The following is a description of a gene set: from publication Abbas AR, Wolslegel K, Seshasayee D, Modrusan Z, Clark HF (PMID 19568420) studied in species Homo sapiens Genes down-regulated in comparison of naive T cells versus effector memory T cells. Human Gene Set: GSE11057_NAIVE_VS_EFF_MEMORY_CD4_TCELL_DN Microarray deconvolution is a technique for quantifying the relative abundance of constituent cells in a mixture based on that mixture's microarray signature and the signatures of the purified constituents. It has been applied to yeast and other systems but not to blood samples. Here we test the ability of this technique to determine the fractions of subsets of memory T cells in peripheral blood mononuclear cell (PBMC) samples., and this is the list of marker genes: NPC1, CD84, SMCO4, B3GNT9, GCLM, MDFIC, LACC1, TMX4, NABP2, ZC3HAV1L, ATXN1, ANXA2, EVI2B, PREX1, MYO1F, CRELD2, RNF149, RORA, RNF126, MFHAS1 (multifunctional ROCO family signaling regulator 1), CLDND1, UST, LGALS1, CD58, ZBTB38, OSBPL3, CREB3L2, LIMS1, SEC11C, CLU, SRGN, RGS3 (regulator of G protein signaling 3), ARHGAP18, ANXA4, ANXA1, PFKL, YWHAH, MIB1, MICAL2, ATP2B4, REEP3, SSR3, TNFRSF4, NCAPH, CAPG, KLRB1, PPIF, TMEM64, GZMK, SAP30, MYBL1, CXCR3, FAS, CDC42EP3, ANTXR2, DUSP16, TBX21, SH3BP5, ADAM19, PPP1CA, RHOU, EFHD2, IFNG, S100A4, CCDC107, PHTF2, MIAT, GBP3, PRR5L, TIGIT, DUSP5, IFI27, CPPED1, GOLGA7, NOD2, NETO2, SLF1, SLC35D2, TMEM200A, CRYBG3, PDIA6, KIF1B, CLIC1, TOR3A, CD63, TTYH2, OGDH, CD28, NMU, MLF1, ACTN4, SMIM29, EIF4EBP2, CBLL1, FBXL8, CD74, EPS15, LGALS3, IL15RA, PEA15, OGFRL1 (NCBI Gene Id 79627), CNPPD1, HLA-DPA1, TLR3, CRIP1, ASB2, PAM, TTC39C, ZNF532, TMEM116, CTSA, NPDC1, NIBAN1, HOPX, MTSS1, DNAI2, MYL6, EIF3A, GDPD5, NECTIN3, CAST, NHERF1 (NCBI Gene Id 9368), TNF, CHST7, SH3BGRL3, PLXNC1, BTG3, FRMD4B, GZMA, RAB27A, RFTN1, TYMP, ITGB1 (NCBI Gene Id 3688), LDHA, CCR6, ST8SIA1, FAR2, SPAG1, TMEM156, SH2D1A, CTSC (cathepsin C), ANXA2P1, TPM4, MATCAP1, CASK, REEP5, PIEZO1, SMAP1, PTTG1, TRADD, ALCAM, AKIRIN2, STOM (NCBI Gene Id 2040), WDR86-AS1, AGO4, MIR22HG, SLC2A3, NINJ2, CCR2 (C-C motif chemokine receptor 2), GLIPR1 (GLI pathogenesis related 1), TXN, IFI16, S100A11 (NCBI Gene Id 6282), AHR, HMGN4 (high mobility group nucleosomal binding domain 4), HNRNPLL (NCBI Gene Id 92906), MIS18BP1, PHACTR2, IL10RA, CDK2AP2, TP53INP1, SPOPL, VCL, STX11, ZC2HC1A, TBCB, AQP3, KIF21A, MAP3K5, ALOX5AP (arachidonate 5-lipoxygenase activating protein), NCF4, LIMS3, CD226, GSTK1, TRAC, ELOVL5, CALHM2, COTL1, CCL5, JPT1, USP46, IQGAP2, UBL3, IQGAP1, NABP1 (NCBI Gene Id 64859), AFDN (afadin, adherens junction formation factor)